Given this list of marker genes Gfi1b, Tmem102, Ccndbp1, Tet3, Scn3a, Pglyrp3, Ttc29, Bscl2, Ccdc9, Shisa5, Caml, Cdc42ep1, Tango2, Tcf7l2, Mast1, Ascc1, Cenpe (centromere protein E), Snta1, Gm11771, Plch1, Mir376b, Phactr4, Mgst2, Mrm2, Slc25a19, Rbpms2, Lrriq4, Sox2ot, Pcmt1, Ube2i, Csdc2, Nop58, Mkln1, Zfp143, Kctd3, Abcb8, Trap1, Ifng, Mtfr1, Rcor3, a, Zeb1os1, Pitpnm2, Lingo4, Mir7035, Nhlrc2, Zfp809, Casp8, Gm26705, Kcnab2, Grm1, Fam76a, Gm23123, Gins2, Slc36a3os, Nav2, Arpp21, Vav1, Eif4a2, Mrpl28, Mir3108, Tgfbr2, Hnrnpu, Sez6, Mir3475, Trp53cor1, Slc22a2, Fxn, 1700023H06Rik, Gm12980, Gna11, Mylpf, Phox2b, Gm26560, Rigi, Mto1, Zbtb8a (NCBI Gene Id 73680), Adarb1, Irf8, Usb1, Cirbp, Ppip5k2, Tnfrsf1a, Gm4342, Mysm1, Gm25224, Olig3, 9130230L23Rik, Agpat2, Pop1, 1810053B23Rik, Gm4349 (predicted gene 4349), Maf, Gm22935, Btnl1, Slc16a4, Atp6v0a1, Tmem131, Gm29718 (predicted gene, 29718), Mir17hg, Uckl1, Tgif1 (TGFB-induced factor homeobox 1), Cbr1, Dars2, Irf3, Hspb6, Lum, Smox, Eva1c, Atg14, E230025N22Rik, App, Gpi1, Dis3l, Phf21a, Lratd1, Ell3, Prss40, Tekt5, Map6, Foxl2os, Ctse, Parp14, Zfp395, Mon2, Slc8a1, Gpr85, Aff1, Rps12-ps26, Mir7664, Gm23090, Gm8957, Fmo1, 4933430H06Rik, Slc35a3, Fbxl22 (F-box and leucine-rich repeat protein 22), Nktr, Fam162b, Gm7442, Or8s8, Rps6kb1, Slc12a6, Gm13689, Gm13529 (predicted gene 13529), Klhl18, Mrpl18, Uhrf1, Gm22270, Triap1, Crppa, Gm22972, Armh3, Atp6v0d1, Gm24068, Ddx23, Garre1, Zfp7, Ext2, Rabgap1l, Vgll4, Atxn3, Top3b, Hoxa11os, Tjp1, Manba, Gm11292, Rtf2, Gm24204, Arhgap45, Pcdhgc5, Hyls1 (HYLS1, centriolar and ciliogenesis associated), Epha10, Gm23407, Stap2, Zp1, 1700022A21Rik, Map1lc3b, Samd10, Mkrn2os, Lgals4, Mb, Atf7ip, Ints5, Palld, Cerkl, Degs2, Mpnd, Lrrc75aos1, Gm14227, Ptpn11, Ezh1, Gm12101 (NCBI Gene Id 631243), Nsa2, Ubap1, Cryl1, Or6c8, Plcd4, Niban3, Akap1, Oas2, Ppfia1, Tank, Nedd9, Nhlrc3, Gm7299 (predicted gene 7299), Plekhg1, Rpf2, Rbm26, Gm25526, Rb1cc1, Safb2, 4930515G01Rik, Gm9078, Ager, Magohb, Mir1946a, Clec2e, Tsg101, 6030468B19Rik, Gm16185, Spag5, Nudt5, Vdac1, Rps27a-ps3, Rgp1, Milr1, Iscu, Rph3a, Slc9a8, Tor1aip2, Gm4877, Uap1l1, Syne4, Tgoln1, 2900079G21Rik, Rfwd3, Map2k1, Klhl12, Gm25848, Ctbp2 (C-terminal binding protein 2), Rfx4, Gas8, Luc7l3, Sag, Stra6, Eva1b, Gm15222, Wdfy3, Supt7l, Trdv2-1, Alyref, Alpk2 (NCBI Gene Id 225639), Timm17a, Ncaph, Rabl6, Paqr8, Or6n1, Thap1, Nup160, Slc4a1ap, Fam98c, Lonrf2, Il4, A230083N12Rik, Thap6, Tbx15, Dnajc11, Klf1, Gm22272, Maged1, Arhgap28, Dnaaf9, Shroom1, Lrrc42, Hhip, Crem, Ficd, Serpinb6e, Arhgap4, Ntan1, 2310011J03Rik, Gm15197, Gpr35, Sptb, Vipr1, Zfp142, Rbm47, Agps, Ttf1, Gm19705, Lztr1, Cdh13, Calcoco2, Nfe2, Gm13094, Gm13010, 4930507D10Rik, Gys2, Islr, Gm34768, Gm11149, Jak1, Parn, Smg5, Tpk1, Ergic1, Emc3, Gm13561, Capn10, Glis3, Gm25608, Mir129-2, Pbrm1, Snf8, Gm22122, Or4c35, Fau-ps2, Gm24978, Mtif3, 1700003F12Rik, Pid1, Rassf3, Suv39h1, Rab27a, Rapgefl1, Gm11637, Gm25489, Snph, Actl6b, Znrf4, Rasa4, Lyg1, Gm26447, Nr6a1os, Trip12, Mzf1, Cfap74, Pvt1 (NCBI Gene Id 19296), Gm6096, Gm18354, Gm14856, Gm8849, Mms19, Rgs11, Phf24, Cct3, Dhx9, Best4-ps, Gm13662, Gm26885, Tomm34, Ube2h, Gmeb1, Tspan8, Clstn1, Atxn2, Il23a, C9, Tnks1bp1, Tcp1, Gnas, Gm16490, Vps72, Gm10268, Golga7, Pole, Tmem61, Nmi, Gm12021, Ints13, Gm5258, Myo15a, Srrm4, Pan3, Man2c1, Rfc4, Gm2800, Pdzd2, Tex9, Adam32, Rpl10-ps2, Eif4e2, Btbd19, Surf6, Rad54l2, Arhgap18, Slc2a9, Prpf38b, Tpd52l2, 2310016D23Rik, Gm9955, Ak4, Jph4, Gm12924, Pkdcc, H2-M5, Csnk1g1, Syngap1, Gm25930, Vdr, Gm11454, Itpr2, Snx1, Hspa9, Gm11197, Oxct1as, P2rx3, Gba2, Plin2, Gm12333, Gm15066, Gm8398, Eif1ad, Dynll2, 9430007M09Rik, H1f11-ps, Trafd1, Uba52 (ubiquitin A-52 residue ribosomal protein fusion product 1), Grin3b, Tdrd9, Cdkn1a, Gpc1, Gm15411, Zbtb43, Rpl38, Eif2b3, Gm29994, Mepce, Stx3, Fndc7, Ankrd1, Mmachc, Btbd10, Bcl7b, Tnfrsf9, Sapcd2, Mindy3, Zic1, Synpo2l, Mir7075, Chek1, Elavl4, Mecr, Rora (NCBI Gene Id 319897), Mettl3, Gm24400, Taf1c, Rffl, 1110059E24Rik, Gm14098, Txnrd1, Wipf1, Pi4ka, Hoxa11 (homeobox A11), Impdh1, Ift122, Orc2, A530064N14Rik, Gm12740, Klk8, Pold2, Uqcrc2, Pate2, Tbc1d9b, Or2n1, Mir103-2, Lrrc4c, Or1e29, Dazap1 (DAZ associated protein 1), Ube2z, Wdr17, Nabp2, Zfat, Gpr84, Rnf125, Rpl22, Klf8, Opcml, Plce1, Itgbl1, Arfgef1, Pomgnt1, Gpr15, Cep85, 9630013K17Rik, Grk5, Dpep2, Psmd4, Rdm1, Adck2, Kif2c, Drosha, Atp23 (NCBI Gene Id 69734), Zfp82, Gm12571, Ptp4a1, Gm12189, Il2ra, Dppa4, Lars1, Cox7a1, Mbtps2, Parp4, Gm12936, Cnbd2, Gm5660, Cenpk, Thpo, Gm34248, Larp1b, Acsbg2, Ccdc185, Il27ra, Alg13, Cltc, Tmem131l, R3hdm2, Ep300, Rps12-ps7, Teshl, Hdac6, Mrpl21, Ccdc88a, Zmat1, Plek, Hapstr1, Srrm1, Pask, Stpg1, Gm14111, Lmo3, Mdk, Mlxip (MLX interacting protein), Ly96, Snhg17, Gfi1, Atp2c1, Nhsl2, Gm11379, Poc1b, Lat2, Gm7891, Fam171b, Sla, Car7, Rpl14-ps1, 4930591A17Rik, Ankrd40, Cd101, Rtl5, Bag5, Zfp784 (zinc finger protein 784), Tfap2b, Uso1 (NCBI Gene Id 56041), Gm15780, Pgap2, Lyl1, Ssrp1, Gm15266, Mfn1, Gm12401, Slx4, Naa16, A530041M06Rik, Rtp3, Mir21c, 4930532M18Rik, Gm15895, Evx1, Mir654 (microRNA 654), Lonp2, Ttf2, Tmco2, Zfp637, Hsp90ab1, Slc36a1os, Pabpc4, 4930568G15Rik, Mrps11, Smad7, Dclre1a, Recql5, Prpf38a, Pgd, Gm5532, Tmem53 (transmembrane protein 53), Prim2, Gm7069, Snord83b, Ndufa10, Snrnp25, A430072P03Rik, Ech1, Habp2, Zfr, Mstn, Klhl22 (NCBI Gene Id 72509), Larp4b, Mir5136, Arrdc3, Ufsp2, Gabrb3, Med18, Mxra8, Clec2d, Dync1h1, Xpnpep1, Gm20544, Nbeal2, Nudt1, Gm6985 (predicted pseudogene 6985), S100a4, Gm11691, Dnajb2 (NCBI Gene Id 76593), Pick1, Sardh, Psmc1, Erg, Fgfr2 (NCBI Gene Id 20946), Rnf181, Gm25826, Nvl, Mmp19, Pkib, Nostrin, Tbx3os1, Dlgap5, Slamf1, Cd9, Gigyf2, Ntpcr, Ltbp1, Hkdc1, Ppp1r3f, Gm30292, Mir376c, Ccdc116, Dgcr8, Nek9, Rbm5, Atxn1l, Bltp2, Rpl31-ps9, Fam186b, Spry4, Ccer2, Pik3cd, Oser1 (NCBI Gene Id 66680), Cse1l, Misp3, Cfp, Cp, P2rx7 (purinergic receptor P2X, ligand-gated ion channel, 7), AA986860, Enah, Spaca3, Gm5129, Defb40, Il17rd, Adcy7, Gm2990, Gm12707, Pnpla3, Prickle4, Zfp819, Trim67, Slc22a19, Gmfg, Rnaseh2a, Thoc1, Mir7057, Mir6944, Gm12340, 4930412F09Rik, Btbd18, Unc13b, Gm8668, Fxr2, Gm16342, Nr1i3, Mindy1, Slc24a2, Gm26070, Gm15927, Ssc4d, Nadk2, Fam216a, Npr3, Pwwp3a, Rgs16, Ppp4r1, Tpd52, Arhgap20, Cplx4, Phex, Ttc14, Cnga3, Gm23341, Phlpp2, Mir6368, Sycp2l, Pde9a (phosphodiesterase 9A), Tm4sf5, Rcbtb1, Stk31, Pknox1, Rab3gap1, Srebf1, 2610206C17Rik, Nbr1, Asah1, 1700120B22Rik, Nell1, Carhsp1, Bcl6, Crcp, Kifbp, Epdr1, Thbs3 (NCBI Gene Id 21827), Mir344c, Gm13110, Mfap1b, Gon4l, Galnt1, Fam83c, Garin2, Gm9599, Dpep3, Nipal3, Trim24, Mir541, Recql, Ep400, Neto1, Or55b4, Plin1, Ssh1 (NCBI Gene Id 384311), Dbn1, Gm24145, Ppp1cb, Cep95, Nmnat2 (NCBI Gene Id 98444), Gm9443, Crybg2, Gm12828, Chrna10, Slc7a7, Plekha5, Prss54, Mamdc4, Slain1, Entpd8, Runx2, Mir1199, Gtf2i, Six6, Gm25609, Snhg14 (NCBI Gene Id 16353), Ncoa4 (nuclear receptor coactivator 4), Syt12, Mroh1, Zfp867, Gjb3, Fcna, Atp8b4, Csde1, Ankrd44, F830112A20Rik, Gm24141, Evl, Ebf2 (early B cell factor 2), Tldc2, Efna3, Slc2a3, Sulf1, Gm19932, Mtf2, Znfx1, Nos1, Sntb2, Mfsd14b, Myh14, Adat1, Tfrc, Lrmda, Bace1, Utp25, Gm10309, Tet1, Rhot1, Vmn1r196, 4933434E20Rik, Necap1, Elavl2, Fam193a, Celf5, Zfp661, Clcn7, Gm23817, Plaa, Rbp4, Amigo1, Hlcs, Pzp, Gm11665, Iqce, Kit, Zfp319, Zpbp2, Nicn1, Rc3h2, Gm15550, Acyp1, Ccl7, Foxm1, Abca16, Nsd3, Zmym4, Aknad1, Neurl4, Rpl30-ps6, Xrcc6, Dph2, Oaz2-ps, Kcnt2, A830031A19Rik, Lcn12, Pdlim1 (NCBI Gene Id 54132), Mpi, Abca4, Rbl2, Fyn, Gak, Rsrc1, Tspyl2 (NCBI Gene Id 77013), Acad11, Entpd1, Gm11872, Hook1, Tlr7, Maea, Gm11198, Fkbp4, Ift140, Gm24878, Dnal1, Zfp957, Aspscr1, Plekhs1, Gm20033, Ctsh, Gm7536, Usp14, Or4n4, Pakap, A430034D21Rik, Igfbp4, St6galnac2 (ST6 (alpha-N-acetyl-neuraminyl-2,3-beta-galactosyl-1,3)-N-acetylgalactosaminide alpha-2,6-sialyltransferase 2), Tmem242, Atrip (NCBI Gene Id 78099), Gm15610, Zmiz2, Or5p52, 4930453N24Rik, Git2, Itih3, Sinhcaf (SIN3-HDAC complex associated factor), Gm30835, Sspn, Rab43, Ninj2, Picalm, Psmd2, Fmo9, Yju2 (YJU2 splicing factor), Snora57, Ube4bos3, Rnf214, Gm25495, Ehbp1, Mfsd2b, Gm26795, Gm25439, Gm29793, Slc25a14, Timm17b, S1pr4, Raf1, 4930512H18Rik, Atp5mj, Gpr68, Lhfpl4, Smco4, Vamp1, Cers2, Lrrc23, Spice1, Cnnm3, Ly6g6f, Zfp748, Ggt7, 4930556N13Rik, 1110028F18Rik, Elk4, Tpr, Adhfe1, Smpd5, Abo, Mir7675, Tenm4, Atp8b3, Tmeff2, Gm24965 (NCBI Gene Id 115490022), Rfx2, Rsph9 (radial spoke head 9 homolog (Chlamydomonas)), 5830487J09Rik, Zwilch, Abcb9, Atp6v1e1, Mir6417, Zdhhc5, Mfsd13b, Lrp2bp, Pde8a, Gm12393, Atp5f1d, Gfm1, Wdr43, Lce3c, Mpzl2, Myom2, Atg2a, Inhbc, Gm15651, Celf1, Mthfsd, Rad54l, Crb2, Oplah, Rbm20, Shmt1, Rnf170, D030068K23Rik (NCBI Gene Id 638445), Ccdc110, Zbtb11, Ubap2, Rpl9-ps4, Ubxn1, Fry (FRY microtubule binding protein), Kcnv2, Rnf220, Psma3, Phgdh, Gzmm, Them5, Anp32e, Nkapl, Tnik, Crot, Gm37885, Jph1, Eno4, Gm12464, Lamp2 (lysosomal-associated membrane protein 2, NCBI Gene Id 16784), Cyp4a28-ps, Slc25a36, Mrpl20, Pgbd1, Ubtfl1, G2e3, Myo5b, Dgkz, Ikzf5, Morf4l1, Chchd10, Mir6367, Ces1d, Gm20404, Eri3, Plcl2, Uba2, Fmc1, 4930509H03Rik, Psph, Gm8883 (NCBI Gene Id 675672), Acap1, Drg1, G6pc3, A330102I10Rik, Znrf1, Ppp4r4, Ralbp1, Slc9b2, Rbmx2-ps, Bcas1 (brain enriched myelin associated protein 1), Grin2a, Foxp1, Plcxd2, Rbbp6, Clstn3, Ubqln4, Lhfpl6, 6230400D17Rik, Slc1a2, Alg11, Gm6209, 4930528J11Rik, Znrd2, Ppp1r10, Vpreb1a, Altre, Mir376a, Fam171a1, Echs1, Spats1, Tap2, Taf6l, Gemin2, Sun1, Sdf2 (stromal cell derived factor 2), Stag1, Gm11444, Cfap69, A630072M18Rik, Nrbp1, Mir6385, Ltbp3, Ube2k, Exosc1, Gm26049, Gm9496, Sptbn2, Tanc1, Clk2, Ywhag, Rsu1, Gm12882, Rbm6, A930001C03Rik, Fcgr3, Pik3r6, 9530068E07Rik, Rhd, Fh1, Crk, B4galt7 (beta-1,4-galactosyltransferase 7), Gm23382, Ifitm10, Mir3966, Hhat, Glrx5, Wfs1, 4930533L02Rik, Fbxo11, 2510002D24Rik, Ccdc121rt2, Dlk1, Camk1, Gm14901, Acsbg3, Gm9359 (predicted gene 9359), Nsun5, Ubap2l, Speg, Pdgfd, Zfp747l1, Six1, Ccdc65, A930018P22Rik, Gm23605, Dus3l, Gm24989 (NCBI Gene Id 115487904), B630019A10Rik, Ccr4, Eps15 (NCBI Gene Id 73669), Mir6365, Fcf1, Gm27005, Agap1, Gm24066, Pnpla7, Ica1l, Fbrsl1, Tmem200a, Gm10069, Pdk1, Eml6, Myo1c, Gm24793, Atrx, Gm6462, Amz1, Togaram2, Gstp2, Acat1, Slc1a1, Fam169b, Smc4, 1700039M15Rik, Platr27, Tcf4, Usp21, St14, Gm15821, Pde4d (NCBI Gene Id 320753), Zfp318, Fuca1, Dnajb6, Gpr107, Eif3d, Cyp4f15, Slit2, Syt17, Gm2474, Or4x12-ps1, Gm6365, Gm5501, Acad9, Lrp2, 2810432F15Rik (NCBI Gene Id 69963), 2310010J17Rik, Polr3f, Trpm2, Ing4, Gnl3, Mir6405, Rnf20, Id3, Atpaf1, Mcf2l, Rogdi, Setdb2, Bdh2, Zmynd12, Slc38a8, Bmal1, Fhip2b, Tcf7, Arl2bp, Sqstm1, Misp, Dnajc13, Kdm3b, Sart3, Sos2, Or1e22, Gm8969, Nhp2 (NCBI Gene Id 68237), Gm24665, Kcnh8, Nkain1, Tex14, Tigd4, Arhgap26, Idh3b, Zfp217, Fastkd5, Copg2 (coatomer protein complex, subunit gamma 2), Thoc2l, Tor1aip1, Baz1b, Or2c1, Gnpat, Runx1, Terf2, Gm20443, Nr3c1, Lypd6b, Fam241b, Papss2, Prrc2c, Pacrg, 4933408N05Rik, 1700109H08Rik, Sema4d, Capns1, C230066G23Rik, Kctd16, Cln3, Sqor, Magi2, Zcchc8, Usp19, Gm15039, Plut, Gm24526, Sec16a, Tulp3, Borcs5, Uba5, Ndfip2, Mgst3, Hsd3b7, Fnbp4, Gm2174, Mgat5, Gm27811 (NCBI Gene Id 115489809), Mvd, Aim2, Gc, Nrl, Zfp512b, Sipa1l3, Nmnat3, Rad51ap2, Fbln2, Faim2, Cfh, Gm12654, 1700101I11Rik, Gm12608, Abcg3 (NCBI Gene Id 27405), Mettl22, Glra2, Gm25973, Fancd2, C230071H17Rik, Usp3, Psmd7, Gm12057, Rasa3, Apob, 5830432E09Rik, Rian, Sp1, Tonsl, Lpcat1, Uts2r, Snapin, Ppp2r5c, Ncoa5 (NCBI Gene Id 228869), Mob4, Gamt, Mrpl22, Trpm1, Gm11191, Tmem252, Gtdc1, Slc36a1, Gm13916, Jakmip1, Hoxa7, Capn11, Gin1, Gss, Col9a3, Vac14, Mir99ahg, Cd164l2, Tsga13, Snora81, Inpp5b, Klf13, Nr1h4 (nuclear receptor subfamily 1, group H, member 4), Mef2b, Ikzf3, Slc36a4, Vcam1, Gm10157, Map4k2, Gripap1, Gm12339, Adamts8, Traj58, Gm14491, Tnks2, Stard9, Phldb2, Tmem161a, Stat5a, Kank3, Slc41a2, Msh3, Aldoa, Epc1, Gm36527, Shbg, Gm16225, Dld, Dyrk4, Itga9, Tle2, Apom, Ahcyl2 (NCBI Gene Id 74340), Mdn1, Gpr157, Alas1, Mov10l1, Ptges3, Hoxc11, 1700025G04Rik, Flad1, Gpn3, Gm12803, Gm25184, Alms1, Raver2, Gm24592, H3f3b, here is a description of the gene set: Mouse Gene Set: ZFP938_TARGET_GENES studied in species Mus musculus from publication Yevshin I, Sharipov R, Kolmykov S, Kondrakhin Y, Kolpakov F (PMID 30445619)